Given this list of marker genes BRMS1, NWD1, ADGRG3, PIAS2, TMIGD3, ADORA3, OTULIN, SIK1, CHUK, COMMD7, ERBIN, SUMO1, TFDP3, PRMT2, RB1, TRAF3, UFL1, COMMD6, ID2, MTURN, NLRC3, TRIM40, FOXS1, NR0B2, GFI1, ZNF431, COMMD1, RWDD3, SIRT1, CACTIN, MAP3K10, CMKLR1, PBX1, PHB2, EIF2AK4, PEX14, POU4F2, MEN1, AIM2, TRIM21, CDK5RAP3, PSMD10, PARP10, FLNA, PIM1, CYLD, LRRC14, CYP1B1, CHP1, ARRB1, ESR1, PAXIP1, NFKBIA, ACOD1, PYCARD, PYDC1, RBCK1, NLRC5, SETD6, HAVCR2, ARRB2, NFKBIL1, TRIM37, BCL3, PYDC2, PKHD1, ID3, NUPR1, USP7, FOXP3, TCEAL7 (NCBI Gene Id 92218), HEYL, RNF2, NLRP2B, CEBPG, ID1, here is a description of the gene set: Any process that stops, prevents, or reduces the frequency, rate or extent of the activity of a transcription factor, any factor involved in the initiation or regulation of transcription. species: Homo sapiens Human Gene Set: GOBP_NEGATIVE_REGULATION_OF_DNA_BINDING_TRANSCRIPTION_FACTOR_ACTIVITY